The following is a description of a gene set: The part of the late spermatid or spermatozoon that contains the nucleus and acrosome. Human Gene Set: GOCC_SPERM_HEAD species: Homo sapiens, and this is the list of marker genes: ACTL9, GARIN3, CYLC1, ALDOA (NCBI Gene Id 226), CCDC38 (NCBI Gene Id 120935), ADAM20, WBP2NL, RHO, ADAM29, DNAJB1, PCDH11Y, TACR2, DDX6, SCAPER, PMFBP1 (NCBI Gene Id 83449), ADAM30, DEFB132, OPN4, ADAM21, CST11, PLCZ1, CAPZA3, GARIN4 (NCBI Gene Id 149647), TACR1